The following is a description of a gene set: studied in species Mus musculus Genes with promoters bound by FOXP3, dependent on it, and up-regulated in hybridoma cells stimulated by PMA and ionomycin. Mouse Gene Set: MARSON_FOXP3_TARGETS_STIMULATED_UP Foxp3+CD4+CD25+ regulatory T (T(reg)) cells are essential for the prevention of autoimmunity. T(reg) cells have an attenuated cytokine response to T-cell receptor stimulation, and can suppress the proliferation and effector function of neighbouring T cells. The forkhead transcription factor Foxp3 (forkhead box P3) is selectively expressed in T(reg) cells, is required for T(reg) development and function, and is sufficient to induce a T(reg) phenotype in conventional CD4+CD25- T cells. Mutations in Foxp3 cause severe, multi-organ autoimmunity in both human and mouse. FOXP3 can cooperate in a DNA-binding complex with NFAT (nuclear factor of activated T cells) to regulate the transcription of several known target genes. However, the global set of genes regulated directly by Foxp3 is not known and consequently, how this transcription factor controls the gene expression programme for T(reg) function is not understood. Here we identify Foxp3 target genes and report that many of these are key modulators of T-cell activation and function. Remarkably, the predominant, although not exclusive, effect of Foxp3 occupancy is to suppress the activation of target genes on T-cell stimulation. Foxp3 suppression of its targets appears to be crucial for the normal function of T(reg) cells, because overactive variants of some target genes are known to be associated with autoimmune disease. from publication Marson A, Kretschmer K, Frampton GM, Jacobsen ES, Polansky JK, MacIsaac KD, Levine SS, Fraenkel E, von Boehmer H, Young RA (PMID 17237765), and this is the list of marker genes: AI504432, Lpxn, Jak2, Cdyl2, Itk, Themis, Mllt3, Ptger4, Slc17a6, Zfp36l1, Tgif1, Tmprss11e, Tnfrsf19, Zap70, Il2, Cytip, Crtam, Slc25a24, Eea1, Mbp, Adam10, Gpr171, Tnfsf14, Phf6, Btla, Pou2af1, Evi2b, Anxa1, Dap, Ptpn22, Kdm2b